The following is a description of a gene set: from publication Fu W, Ergun A, Lu T, Hill JA, Haxhinasto S, Fassett MS, Gazit R, Adoro S, Glimcher L, Chan S, Kastner P, Rossi D, Collins JJ, Mathis D, Benoist C (PMID 22961053) Genes down-regulated in CD4 T conv over-expressing: FOXP3 versus PBX1 and FOXP3. species: Homo sapiens The transcription factor FoxP3 partakes dominantly in the specification and function of FoxP3+ CD4+ T regulatory cells (Tregs), but is neither strictly necessary nor sufficient to determine the characteristic Treg transcriptional signature. Computational network inference and experimental testing assessed the contribution of several other transcription factors (TFs). Enforced expression of Helios or Xbp1 elicited specific signatures, but Eos, Irf4, Satb1, Lef1 and Gata1 elicited exactly the same outcome, synergizing with FoxP3 to activate most of the Treg signature, including key TFs, and enhancing FoxP3 occupancy at its genomic targets. Conversely, the Treg signature was robust to inactivation of any single cofactor. A redundant genetic switch thus locks-in the Treg phenotype, a model which accounts for several aspects of Treg physiology, differentiation and stability. Human Gene Set: GSE40274_FOXP3_VS_FOXP3_AND_PBX1_TRANSDUCED_ACTIVATED_CD4_TCELL_DN, and this is the list of marker genes: REL, CD200, IGF2R, AMIGO2 (NCBI Gene Id 347902), CAP2, FANCI, AVPI1, RASA3, SDC4, TCF7, CCDC157, BBS5, DGAT2, MMP11, PROCR, FLYWCH1, NR4A3, PATJ, BIRC2, PLEKHO1, ZFP30, MARVELD1, ZBED5, HOMER1, ATP9A (ATPase phospholipid transporting 9A (putative)), TTC8, ADAMTS6, ARMCX1, DDR1, SMAD7, PTPRF, SRCAP, DCAF17, CNOT10, SATB1, CELSR2, SH3PXD2A, TTC3, AGTPBP1, PADI1 (peptidyl arginine deiminase 1), ABCA1, INF2, SKI, RASA2, YPEL2, HLA-DMA, LTA, KIT, IFI44L, TUBB2B, INSL6 (insulin like 6), PRMT2 (protein arginine methyltransferase 2, NCBI Gene Id 3275), CCR7, NCF1, THEMIS, BCL2L13, NSUN4, LETM2, STAT5B (NCBI Gene Id 6777), TMIE, PCNX1, PEX5, WIPI2, NFASC, CCND3, CCR6, IGSF3, ETS2, PKP4, ZMIZ2, PARP11, HDAC1, SECTM1, CYBRD1, SLC44A1, MX1, ARHGAP20, SCIN, AP1M2, PTPRS, P2RY14, KCTD6, PI4K2B, ACSS2, STIM2, FCRL1, FABP5, IFIH1, ALDH18A1, FOSL2, MARCHF9, ANKRD46, GPRASP2, ZSCAN12 (NCBI Gene Id 9753), SOX4, MYB, TP53I13, MAN1A1, CHCHD6, SERPINI1, TMEM120B, BCL3, BASP1, ZFTA, UBQLN4, MCUB, MAPK11, MADCAM1, RALGPS2, IFIT1B, C14orf28, USP18, IER5L, IRAK1BP1, CDK20, PCGF5, PMEPA1, GOLGB1 (golgin B1), MAP7, ARID5A, SRSF12, IL1R2, MCCC1, DHX58, MBNL3, SMAD1, IFITM3, SLC22A2, TNFSF8, ACADM, IFT80, PIP4K2A, RELB, ABCG2, C11orf24, NOD1, MAP4K3, ADGRL1, RNF213 (ring finger protein 213), CYP8B1, TCTN3 (tectonic family member 3), CARNMT1, TRAF4, FCHSD2, DAPK1, PLSCR3, CAVIN1, RAB3IP, ABCC1, XPO4, FMNL3, DNAI4, CTSW, IKZF4, FAM118A, PDGFB, FBXW9, B4GALNT1, QPRT, SLC12A2, DNMT3A, GNA12, YPEL3, TMEM131, SALL2, SHANK1, UBTD2, BHLHA9, AHCYL2, ATXN2, ZC3H12D, HMGN3, POGK, SPECC1, NICN1, PLA2G4F, TP53BP1, ID1, EPB41L2, ADCY6, NFKB2, RNF144A, SH3BP5, RTL5, IFI44, SAPCD1, TTYH3, STAT5A, TCF4, ST8SIA1, PER1, ABCG1, CACNB3, AHI1, NIBAN3, IFITM2, RNF157, CCR9, CHPT1